Given this list of marker genes BMAL1, MAPK1, FOS, RBFOX3, RET, ARNT2, MAPK3, BDNF, MDM2, CREBBP, CDK5, INS, SYT10, GEM, NAMPT, MAGED1, IQSEC3, PLK2, CDK5R1, NPAS4, ARNT, XPO1, here is a description of the gene set: Reactome Pathway: NPAS4 regulates expression of target genes NPAS4 is a basic helix loop helix (bHLH) transcription factor that needs to dimerize with another bHLH protein, either ARNT, ARNT2 or ARNTL, in order to be able to bind to target DNA.<br><br>NPAS4 is implicated as a transcriptional regulator of genes involved in neuronal development such as CDK5, CDK5R1, RBFOX3 (NeuN), BDNF and RET, genes involved in synaptogenesis and synaptic transmission such as NPTX2, MDM2, FOS, IQSEC3, PLK2 and possibly other genes, circadian rhythm-related genes such as NAMPT, and genes involved in neuroprotection upon injury such as GEM, SYT10 and possibly other genes. In pancreatic beta-cell, NPAS4 is implicated as a regulator of insulin synthesis under stress conditions.<br><br>The circadian clock regulated gene CRY1 was identified as NPAS4 target gene in sheep brain. The DBNL gene, encoding Drebrin, a dendrytic cytoskeleton modulator, was identified as a gene directly upregulated by Npas4<br><br>NPAS4 is expressed in endothelial cells and may play a role in angiogenesis.<br> part of: Transcriptional Regulation by NPAS4 studied in species Homo sapiens